Given this list of marker genes Snw1, Ep300, here is a description of the gene set: This event has been computationally inferred from an event that has been demonstrated in another species.<p>The inference is based on the homology mapping from PANTHER. Briefly, reactions for which all involved PhysicalEntities (in input, output and catalyst) have a mapped orthologue/paralogue (for complexes at least 75% of components must have a mapping) are inferred to the other species. Reactome Pathway: NOTCH1 Intracellular Domain Regulates Transcription species: Mus musculus electronically inferred by orthology from the curated human pathway part of: Signaling by NOTCH1